The following is a description of a gene set: Any process that activates or increases the frequency, rate or extent of epithelial cell differentiation. Mouse Gene Set: GOBP_POSITIVE_REGULATION_OF_EPITHELIAL_CELL_DIFFERENTIATION studied in species Mus musculus, and this is the list of marker genes: Trp73 (NCBI Gene Id 22062), Kdf1 (NCBI Gene Id 69073), Dmbt1 (NCBI Gene Id 270001), Bmp6, Sfrp4, Pax8, Rfx3, Wnt10b, Bmp4, Sox2, Nme2, Foxc1, Prkch, Sox9, Ptch1, Atoh8, Foxn1, Cyp27b1, Ncoa3, Bad, Tmem100, Pax2, Sfn, Btg1, Cdkn2b, Bmp2, Numa1, Macroh2a1, Zeb2, Skint1, Mesp1, Foxj1, Cd24a (CD24a antigen), Sult2b1, Pax6 (paired box 6), Commd5, Etv4, Vdr, Notch1, Ptch2, Gdf2, Ahi1, Vezf1, Fgf2, Atoh1, Wnt9a, Pax4, Lef1, Serpine1, Bmp7, Ipo7, Etv2, Nkx2-2, Acvrl1, Rptor, Ctnnb1, Med1, Pkp1 (NCBI Gene Id 98390), Prom1, Lhx1 (LIM homeobox protein 1), Alox8, Gdnf (NCBI Gene Id 14573), Ovol2, Lif, Macroh2a2, Foxa3